The following is a description of a gene set: species: Mus musculus Mouse Gene Set: GOBP_PEPTIDYL_ARGININE_METHYLATION The addition of a methyl group to an arginine residue in a protein., and this is the list of marker genes: Ndufaf7, Prmt8, Prmt5, Prmt7, Prdm1, Prmt1